The following is a description of a gene set: studied in species Mus musculus Mouse Gene Set: GOBP_NEGATIVE_REGULATION_OF_STEM_CELL_POPULATION_MAINTENANCE Any process that stops, prevents or reduces the frequency, rate or extent of stem cell population maintenance., and this is the list of marker genes: Ing2, Hdac1, Zfp706, Rbbp4, Hdac2, Arid4a, Rbbp7, Tet1, Hnf1b, Sinhcaf, Brms1l, Sap30, Arid4b, Suds3, Loxl2, Sin3a, Wnt9b, Pax8, Ing1, Pax2, Ogt, Sap130, Brms1, Sap30l, Bmp7